Given this list of marker genes Suv39h1 (NCBI Gene Id 20937), Zbtb41, Arhgap29, Myocd, Klhl14, Krtap4-2, Kcnd2, Cep170, Dcun1d3, Rab5c, Kdm1b (NCBI Gene Id 218214), Vps26a, Cbln3, B3galt2, Mob1b, Myrf, Lratd2, Dkk1, Angel1, Fat2, Mtmr4, Arhgap26, Atp2b4, Arhgef12, Trmt2a, Znrf3, Oga, Socs5, Lman2, Hipk3 (NCBI Gene Id 15259), Gcm2, Osr1, Kif5b, Dll1 (delta like canonical Notch ligand 1), Casp2 (caspase 2), Tapt1, Ago1, Zfhx4, Dpysl5, S1pr1, Prr23a1, Scml2, Skida1, Chd5, Rbl2, Rab5b, Zfp367, Ssbp1, Miga2, Prdm8 (PR domain containing 8), Fgf9, Ppp2r2a, Zbtb7a, Glod4, 2010106E10Rik, Zfp160, Dazap2, Nfx1, Tmem38b, Zbtb5, Myoz2, Nr4a2, Ankrd9, Cxcr4, Tnik, Irf2bp2, 2510009E07Rik, Cpeb1, Arhgef28, Mat2b, Zc3h12c, Lamp5, Nol4l, Foxj3, Irf4, Ccng2, Rtn1, Mylk, Mrtfb, Ppp4r3b, Tenm2, Ifi209, Zfp148, Tfap4, Clock, Rnf216, Dixdc1, Npas2, Rrm2, Bin3, Synpo2, Btg1, Rtn4, R3hdm1, Nedd4l, Eif5a2, Thsd7a, Dnajb3, Ikzf2, Caprin2, Hp1bp3, Epha7, Rcan3, Ahcyl1, Slc25a13, Igsf10, E2f2, Sertad2, Syncrip, Phf1, Dync1li2, Nbea, Pafah1b2, Stil, Arid4b (NCBI Gene Id 94246), Mef2a, Ube3c, Arid4a, here is a description of the gene set: from publication Chen Y, Wang X (PMID 31504780) species: Mus musculus Mouse Gene Set: MIR_467A_5P Genes predicted to be targets of miRBase v22 microRNA mmu_miR_467a_5p in miRDB v6.0 with MirTarget v4 prediction scores > 80 (high confidence targets).